Given this list of marker genes Stmn1, Atp2a3, 1110065P20Rik (NCBI Gene Id 77650), Med20, Lcn3, Vapa, Klf12, St6galnac3, Ube2e2, Xpo7, Acacb (NCBI Gene Id 97267), Slc51a, Retreg2, Cpne5, Stim1, Ctbp2, Tada2b, Prkg1, Cyp11b1, Zmiz1, Trib2, Gdap1l1, Iftap, Opn1mw (opsin 1 (cone pigments), medium-wave-sensitive (color blindness, deutan)), Snx18, B3galt5, Hccs, Spint1, Pla2g15 (phospholipase A2, group XV), Crtc3, Map2k7 (NCBI Gene Id 26400), Prkaca, Sh3bp5l, Mllt1 (myeloid/lymphoid or mixed-lineage leukemia; translocated to, 1), Tepsin, Psd3 (NCBI Gene Id 80295), Fkbp1a, Tigar, Usp15, Entpd6, Atosa, Shisal1, Ensa, Kif21b (kinesin family member 21B), Mapk4, Ndst1, Tmbim6, Pabir2, Calr, Ywhaz, Mxd1, Antxr1 (NCBI Gene Id 72182), Slc25a13, Lig3, Traf3ip2, Dusp3, Gja1, Ptgr3, Slf2, Plekhb1, Ermard, Cry2, Dbpht2, Hivep3, Vps37d, Maz, Cimap1d (CIMAP1 family member D), Lce1c, Tbx19, Galnt2, Zmym4, B4galt1, Smg6, Vamp3, Cdyl, Oxr1, Shank2, Cwf19l2, Vps25, Prr12, Ppp6r1, Emc10, Tmed10, Pdcd6ip, Cct3, Cacna1e, Abhd15, Mat1a, Vti1b, Igdcc4, Lypd1, Nudt16l1, Ap5m1, Atf7, Cdcp1, Lpar2, Mmp17, Nudt19, Yme1l1, Fscn1, Diras1, Supt16, Pacs2, Prl4a1, Dpagt1, Taf7l, Dag1, Dusp13a, Cntnap1, Grm8, Spag9, Elmo2, Atp2b4, Glt1d1, Atp11a, Akap6, Plxna4, Usp48, Slc35f1, Sars1, Unc50, Eif1, Tmem201, Castor2, Ccnjl, Ppme1, Smoc1, Sncb, Kcnb1, Cdc42bpa, Phf19, Fam163b, Pitpnm2, Ablim3, Rusc1, Plcb2, Cacna1c, Notch3, Cyb561a3, Cyp26b1, Fgr, Onecut2 (NCBI Gene Id 328974), Rtf1, Atcay, Trim62 (NCBI Gene Id 67525), C2cd2l, Dzip1, Dnaja4, Slc23a2 (NCBI Gene Id 99086), Fbxl7, Entrep2, Serpinb9c, Nacc1, Cdk19, Mmab, Pik3ca, Ccnf, Kti12, Plxnd1, 2310011J03Rik, Hapln4, Phyhd1, Micall1, Ubap2l, P2ry4, Tufm, Prx, Kif5a, Szrd1, Rgs7bp (NCBI Gene Id 77218), Aox1, Dazap2, Sh2d3c, Kat2a, Fitm2, Sypl2, 1700010I14Rik, Sall3, Mamld1, here is a description of the gene set: species: Mus musculus Mouse Gene Set: MIR_6987_5P Genes predicted to be targets of miRBase v22 microRNA mmu_miR_6987_5p in miRDB v6.0 with MirTarget v4 prediction scores > 80 (high confidence targets). from publication Chen Y, Wang X (PMID 31504780)